The following is a description of a gene set: Human Gene Set: HP_ABNORMAL_CIRCULATING_GLYCINE_CONCENTRATION Any deviation from the normal concentration of glycine in the blood circulation. Abnormal circulating glycine concentration studied in species Homo sapiens, and this is the list of marker genes: BOLA3, NFU1 (NCBI Gene Id 80767), GLDC, PET117, SLC6A18, SLC36A2, IBA57, PCCB, PNPO, SLC6A19, IRF6, COX8A, GCSH, SLC7A7, GLYCTK, SUCLG1, LIPT2, SLC30A10, AMT, MMAB, GLRX5, MMAA (metabolism of cobalamin associated A), ATP5F1A, PCCA, NFS1, PHGDH (NCBI Gene Id 94672), MMUT (NCBI Gene Id 4594), SLC6A20, PSAT1, ALDH4A1